The following is a description of a gene set: species: Mus musculus Cytokines mediate cell-cell communication in the immune system and represent important therapeutic targets. A myriad of studies have highlighted their central role in immune function, yet we lack a global view of the cellular responses of each immune cell type to each cytokine. To address this gap, the authors created the Immune Dictionary, a compendium of single-cell transcriptomic profiles of more than 17 immune cell types in response to each of 86 cytokines (>1,400 cytokine-cell type combinations) in mouse lymph nodes in vivo. A cytokine-centric view of the dictionary revealed that most cytokines induce highly cell-type-specific responses. For example, the inflammatory cytokine interleukin-1β induces distinct gene programmes in almost every cell type. A cell-type-centric view of the dictionary identified more than 66 cytokine-driven cellular polarization states across immune cell types, including previously uncharacterized states such as an interleukin-18-induced polyfunctional natural killer cell state. Mouse Gene Set: CUI_B_CELL_IFNG_RESPONSE_UP from publication Cui A, Huang T, Li S, Ma A, Pérez JL, Sander C, Keskin DB, Wu CJ, Fraenkel E, Hacohen N (PMID 38057668) Genes positively differentially expressed in cell type: B cell upon treatment with cytokine: IFN-γ in mouse lymph nodes in vivo., and this is the list of marker genes: Trim12a, Ifi47, Slc9a8, Psme2, Irgm1, Slfn2, Hbs1l, Pdia6, Gbp4 (NCBI Gene Id 17472), Slfn1, Tgtp2, Phc2, Cfl1, Ifi213, Elk4, Rnf213, Bst2, Mpeg1, Pmpca, Notch1, Psma4, Ffar1, Ly6a, Pdia3, Socs1, Ifi209, Zup1 (zinc finger containing ubiquitin peptidase 1), Mndal, N4bp1, Rtp4, Phf11b, Sp140, Exosc1, Gbp3, Serpina3f, Unc93b1, Fbxo4, Isg20, Atm, Wdr36, Nup210, Gbp2, Nampt, Tor3a, Nlrc5, Bccip, Trim21, Cstf3, Ifi208, Gbp5, Cd274, Arl5a, Pml, Ctss, Pfkp, Calhm6, Plac8, Igtp, Zbp1, Gadd45b, Max, Cybb, Irf8, Psmb10, Psmc3, Samhd1, R3hdm4, Ifitm3, Psmb9, Stat2, Hmgn3, Tap1, Wars1, Cmpk2, Nufip1, Ppa1, Gbp7, H2-T23, Litaf, H2-K1, Sdf2l1, Tlr7, Nrip1, Psme1, Copa, Trafd1, Selenow, Ifi214, Psma7 (NCBI Gene Id 26444), Ccnd2, Tapbp, Mettl1, Rab19, Tuba1b, Xrn1 (5'-3' exoribonuclease 1), Cd47, Man2a1 (mannosidase 2, alpha 1), Uvrag, Parp14, Gimap4, Rbm3, Irf1, Pkib (protein kinase inhibitor beta, cAMP dependent, testis specific), Ms4a4c, H2-T22, Icam1, Hadhb, Parp9, Tmsb10, Nmi, Herc6, Sp110, Isg15, Psmb8, Ifi27l2a, Tapbpl, Serpina3g, Aamp, B2m, Stat1, Plaat3, Xaf1, Ltv1, Dbnl, Gbp9